Given this list of marker genes GIT1, CKAP5, HSPA1A, PDE4DIP, DCTN1, PAK1, MECP2, HSPA1B, here is a description of the gene set: species: Homo sapiens Human Gene Set: GOBP_POSITIVE_REGULATION_OF_MICROTUBULE_NUCLEATION Any process that increases the rate, frequency or extent of microtubule nucleation. Microtubule nucleation is the 'de novo' formation of a microtubule, in which tubulin heterodimers form metastable oligomeric aggregates, some of which go on to support formation of a complete microtubule. Microtubule nucleation usually occurs from a specific site within a cell.